The following is a description of a gene set: Any process that activates, maintains or increases the frequency, rate or extent of axon extension involved in axon guidance. Human Gene Set: GOBP_POSITIVE_REGULATION_OF_AXON_EXTENSION_INVOLVED_IN_AXON_GUIDANCE studied in species Homo sapiens, and this is the list of marker genes: BMPR2, VEGFA, MEGF8, CXCL12, NRP1, SEMA5A, DSCAM